Given this list of marker genes Drd1, Ckap5, Epm2a, Comt, Dgki, Atp1a3, Shank1, Kalrn, here is a description of the gene set: Mouse Gene Set: GOBP_HABITUATION A decrease in a behavioral response to a repeated stimulus. This is exemplified by the failure of a person to show a startle response to a loud noise that has been repeatedly presented. species: Mus musculus